The following is a description of a gene set: Human Gene Set: HP_PERIPHERAL_HYPOMYELINATION species: Homo sapiens Reduced amount of myelin in the nervous system resulting from defective myelinogenesis in the peripheral nervous system. Peripheral hypomyelination, and this is the list of marker genes: FGD4, EGR2, DHX16, CTDP1, KCNJ10, SOX10 (NCBI Gene Id 8223), HK1, ADCY6, FIG4